The following is a description of a gene set: species: Homo sapiens Small monomeric GTPases. Human Gene Set: MODULE_86, and this is the list of marker genes: HRAS, MX2, ARL3, RHEB, GSPT1, RAB1A, RHOQ, RAP1A, KRAS, RAB29, RAN, ARF4 (NCBI Gene Id 378), ARF5, ARL4C, RAB4B, ARL1, GBP1, RRAGA, RAB10, RHOH, RAB27A, ARF6, RAB5A, EIF5, RALB, TRIM23, EIF2S3, RAB8A, CDC42, RRAS, RIT1, RAC1, RAB31, RAB2A, GNL2, GEM, GNG10, RAB5C, RALA, RAP2A, ARF1, RAP1B, RAB11A (NCBI Gene Id 8766)